The following is a description of a gene set: Human Gene Set: GOBP_LEUKOTRIENE_D4_BIOSYNTHETIC_PROCESS studied in species Homo sapiens The chemical reactions and pathways resulting in the formation of leukotriene D4., and this is the list of marker genes: GGTLC1, GGTLC3, GGT2P, GGTLC2, GGT1, GGT5, GGTA1, GGT7, GGT6, GGT3P (NCBI Gene Id 440802)